The following is a description of a gene set: Human Gene Set: GOBP_POSITIVE_REGULATION_OF_DEVELOPMENTAL_PIGMENTATION Any process that increases the frequency, rate or extent of the developmental process that results in the deposition of coloring matter in an organism. species: Homo sapiens, and this is the list of marker genes: BLOC1S5, BAX (NCBI Gene Id 581), ZEB2, HPS4, BLOC1S6, ADAMTS9, BCL2, ADAMTS20 (ADAM metallopeptidase with thrombospondin type 1 motif 20), KITLG